Given this list of marker genes KAT6A, MOB3B, SLC35E2A, TNFSF12, PLAGL2, BCAT1, ITGB1BP1, DHRS3, ARFGEF3, KDM6B, CDK11B, PSD2, SLC6A17, PHYHIP, ARF3, MECP2, EAF1, CAMK1D, ZSCAN12, VAPA, ZNF581, SEC24C, ZER1, SCN3B, GHDC, USB1, NOVA2, CD22, MR1, TCF21, AP1G1, HDGF, EFNA2, PXYLP1, LONRF2, FAM185A, PYGM, MLLT10, IRF6 (NCBI Gene Id 7452), LSM12, TBC1D12, KPRP, CDH5, EZH1, SBK1 (NCBI Gene Id 388228), DLX3, ALPK3, NUDC, LYPLA2, RGL2, HR, VIPR1, CLCF1, CACNA1G, SERPINB8 (NCBI Gene Id 5271), DNAJC5G, PPP1R15B, CDIN1, NECTIN1, UNC5D, OTULIN, CIPC, IRX6, BAZ2A, MGA, GLUL, FGFR2, ERC1, MBD6 (methyl-CpG binding domain protein 6), KCNK3, SC5D, MSR1, GRIK1, GEMIN2, ZNF532 (NCBI Gene Id 55205), CREB3L1, ATG2A, ZNF704, ZC4H2 (NCBI Gene Id 7493), PITPNM2, XPC, SLC16A2, SRD5A3, CDK11A, CFAP47, DNAAF3, PLEKHG3, PACSIN1, KCNAB2, SENP3, CLCN6, PATZ1, ADGRE3, SLC35E2B, SLC12A6, C1orf21, SNX22, HYAL3, KCNQ5, ZDHHC3, MTCL2, KIAA0040, SLC35A4, ESS2, MMP25, PTGDS, SLC25A35, CISD1, PLAT, LARP4B, ATOSB, APOBEC3H, NOVA1, GMEB1, DTNA, NATD1, KCNMB1, GNG13, RUFY4, SRMS, MPV17, DAZAP2, ELAVL2, CYP1B1, DENND10, MLLT1, ADRB3, ZSCAN22, CD28, ZNF213 (zinc finger protein 213), ZNF407, KRT76, SLC1A6, here is a description of the gene set: Genes predicted to be targets of miRBase v22 microRNA hsa-miR-4481 in miRDB v6.0 with MirTarget v4 prediction scores > 80 (high confidence targets). from publication Chen Y, Wang X (PMID 31504780) Human Gene Set: MIR4481 species: Homo sapiens